The following is a description of a gene set: An abnormality of an extraocular muscle. Human Gene Set: HP_ABNORMALITY_OF_THE_EXTRAOCULAR_MUSCLES studied in species Homo sapiens Abnormality of the extraocular muscles, and this is the list of marker genes: TUBB3, LIG3, RRM2B, TUBB2B, COL25A1, TUBA1A, POLG, MATR3, PHOX2A, KIF21A, TYMP